Given this list of marker genes Zmynd11, Hras, Ckmt1, Mir19b-1, Pam16, Gstp3, Tsc22d3, Ncl, Pttg1ip, Rps6ka1, Htt, Ramp2, Dyrk3, Klhl20 (NCBI Gene Id 98385), Erbb2, Hsp90b1, Mir292, Hspb2, Nod2, Mir93, Cx3cr1, Aifm2, Atad3a (NCBI Gene Id 71964), Lep, Nono, Fnta, Tcim, Prkdc, Grik2, Irs2, Tmbim6, Pcid2, Ffar4, Notch1, Hsp90ab1, Rock1, Hmga2, Mapk8ip2, Arhgap10, Kank2, Bcl2l12, Dnajc3, Flt4, Bcl3, Pdpn, Lrrk2, Phip, Slc1a1, Lims1, Chd8, Fcgr2b, Zfand6, Sirt1, Stradb, Cib1, Ung, Tnf, Ctnnb1, Rxfp2 (relaxin/insulin-like family peptide receptor 2), Hypk, Taf9, Insl3, Vtcn1, Kifap3, Alms1, Nr4a3, Rad21, Smo, Pdk4, Casp2, Cabin1, Pdxk, Tfap2d, Adam8, Atg7 (autophagy related 7), Sox8, Tmf1, Dspp, Cdc73, Csf2, Higd1a, Slc7a5, Bbs10, Lhx3, Grem1, Eif2a, Nnt, Oxr1, Gbe1, Fas, Ddias, Igf1r, Trp53, Pak4, Pink1, Vdac1, Fga, Pdgfrb, Rack1, Serpinb9g, Coro1a, Nr1h4, Epha4, Grk2, Tnfrsf23, Tsc22d1 (TSC22 domain family, member 1), Vegfa, Anp32b (NCBI Gene Id 67628), Bcl2, Serpinb9c, Ptcra, Nupr1 (NCBI Gene Id 80556), Glo1, Fzd1 (NCBI Gene Id 14362), Rgl2, Eif5a, Grm7, Pcp4, Mdm2, Itgb1 (NCBI Gene Id 70812), Kitl, Rnf7, Cav1, Csnk2a1, Ascl1, Asns, Tmem215, Npy5r, Cxcr3, Rnu12, Por, Arnt2, Gata2, Sct, Smarca4, Dusp1, Birc5 (NCBI Gene Id 11799), Becn1, Dsg2, Mael, Scg2, Apoe, Egfr, Aamdc, Nrbp2, Hif1a, Alox12, Egr3, Eya2, Ybx3, Pcdhgc3, Mnat1, Hand2, Gch1, Tle1, Ube2z, Ntf3, Tnfsf4, Ghitm, Mir92-2, Nkx3-2, Axl, Plxnd1, Icam1, Slc9a1, Cebpb, Arf4, Ell3, Tfap2a, Naa15, Asic2, Mecp2, Zfp385a, Ltk, Gcm2, Hnf1a, Il7r, Pdx1, Pdcd1, Bhlhb9, Vdac2, Pin1, Evi2b, Hsph1, Il3, Acot1, Grin1, Mydgf, Pdpk1, Trip10, Ednra, Ntrk1, Gapdhrt2, Tnfrsf1a, Prkcz, Ccn1, Fkbp8, Msx2, Isl1, Apip, Gata4, Hspa8, Bag6, Brca1, Golph3, Tmbim4, Cdkn1b, Fgf4, Wnt1 (NCBI Gene Id 22408), Pou3f3, Nr3c1, Dpp8, Pik3cg (NCBI Gene Id 76039), Aqp1, Hsh2d, Bok, Vstm2l, Tmem109, Ccl5, Mfn2 (NCBI Gene Id 170731), Mir293, Caap1, Fgf21, Blvra, Cacna1a, Foxc1, Eef2k, Il6st, Ccl19-ps6 (C-C motif chemokine ligand 19, pseudogene 6), Rbck1, Mapk8ip3, Naa16 (NCBI Gene Id 66897), Noc2l, Hdac2, Mif, Efna1, Cdkn2d, Hmgcr, Mt3, Yme1l1, Bnip3, Prdm9, Hnrnpk, Prelid1, Tgfb3, Tjp1, Ccl19-ps4, Ndufa13, Psme3, Plac8, Map2k5, Mre11a, Ntsr1, Herpud1, Cpeb4, Mir25, Pa2g4, Plcg2, Atoh1, Ufm1, Adar, Pin1rt1, Ppp1r10, Serpinb2, Cflar, Itga6, Bard1, Nos1, Tbx1, Gas1 (growth arrest specific 1), Ndufs3, Cdk11b, Nfatc4, Slc39a10, Gpam, Map3k7, Rps6kb1, Ptgs2, Gcg, Gata6, Pim2, Ccnd2, Npc1, Gdf5, Twist2, Mir106a, Rgn, Mir20a, Oog3, Hey2, Nr4a2, Timp1, Niban2 (NCBI Gene Id 227737), Wfs1 (NCBI Gene Id 22393), Fgf10, Maea, Hnf1b, Itprip, Fmn2, Stk40, Tslp, Ptk2b, Gapdh, Grk1 (NCBI Gene Id 24013), Bcl11b, Ambra1, Ptrh2, Ccl19, Pou3f4, Pax2, Cbl, Tcf7, Camk1d, Proc, Grina, Sycp2, Aars1, Bcl2a1a, Mir294, Nme5, Rpl10, Pkhd1, Foxb1, Sphk1, Faiml, Btc, Myc, Mgmt, Myocd, Foxo1, Mrtfa, Mdk, Bfar, Xpnpep1, Hspb6, Met, Pik3r1, Tmbim1, Hmgb2, Prokr1, Ngf (nerve growth factor), Cited1, Lcn2, Fbxo7, Lgmn (NCBI Gene Id 19141), Nat8b-ps, Foxq1, Slc46a2, Epor, Pramel7, Ada, Lmna, Abl1, Apbb2, Rbfox2, Prkca, Ndufaf4, Prop1, Jak3, Srsf6, Park7, Pcdhgc4, Prkch, Cdkn1a, Cxcl12, Creb1, Atf5, Abraxas2, Bmf, Taf9b (TATA-box binding protein associated factor 9B), Ppif, Nefl, Ghrh, Cblb, Opn3, Epcam, Pdcd10, Faim, Gpx1, Fcer1g, Plaur, Grk5, Optn, Mir106b, Twist1, Nqo1, Hsf1, Serpinb9f, Osr1, Pramel1, Ercc5, Xrcc4, Ddx3x, Kcnh8, Pim1, Dpep1, Fgfr2, Tbx3, Rpl10-ps3, Msh2, Btg2, Madd, Xbp1, Rffl, Flna, Nppc, Xiap, Itgav, Card14, Clec5a, Ccl19-ps1, Ednrb, Glp1r, Ucp2, Drd3, Chst11, Prdx5, Esr2, Tgfb2, Pak2, Jun, Spry2, Mtor, Il19, Hyou1, St6gal1, Bax, Map2k1, Pcgf2, Prkcq, Birc7, Klf4, Prr5, Erfe (erythroferrone), Hcls1, Cep63, Agtr1b (angiotensin II receptor, type 1b), Asah2, Lhx4, Map4k4, Gpi1, Foxp1, Agtr2, Retreg1, Casp8, Slc40a1, Itpr1, Sod1, Pik3cb, Syvn1, Tmem161a, Stxbp1, Laptm5, Naip6, Cryab, Myo18a, Ccl21f, Dipk2a, St3gal1, Bcl10, Dock8, Slc25a27, Krt18, Tax1bp1, Nrg1, Stub1, Abcc9, Marchf7, Mtnr1b (melatonin receptor 1B), Smad6, Ptms (NCBI Gene Id 69202), Gria4, Cd38 (CD38 antigen), Arl6ip1, Eno1b, Akr1b1 (aldo-keto reductase family 1 member B), Mfsd8, Dhrs2, Trap1, Gimap3, Creb3l1, Prok2, Ccr5, Kdm2a, Map3k12, Kdr, Hipk3, Fgf2, Syngap1, Fmr1, Avp, Bhlhe23, Hax1, Gstp2, Tgfa, Triap1, Ing2, Gnai3, Pepd, Prlr, Lrp2, Wnk3, Ogg1 (8-oxoguanine DNA-glycosylase 1), Gnaq, Map2k4, Ciapin1, Lrp6, Smad5, Sox9, Ntf5, Mcl1, Ppara, Faim2, Mapk8ip1, F2r, Shc1, Bak1, Fadd, Cited2, Msx1, Il13, Ccnd1, Maz, Cth, Adora1, Tcf7l2, Ccl19-ps5, Tigar, Adamts20, Sh3glb1, Serpine1, Ctns, Bmi1, Ccl21a, Muc4 (mucin 4), Selenos, Supv3l1, Ptprz1, Ier3ip1, Crhr1, Dll1, Dnaja1, Dnaja3, Kdm2b, Ngfr, Bag5, Fgg, Hip1r (huntingtin interacting protein 1 related), Epo, Rps6, Rnf34, Serpinb13, Shh, Mical1, Fgb, Dstyk, Qars1 (NCBI Gene Id 97541), Serpinb9e, Ackr3, Atad5, Atp6v0c, Grn, Insl6, Pias1, Il2rb, Naa38, Eya1, Jak2, Clu, Ghsr, Bdnf, Ddr2, Fxn, Rnf144b, Nuak2, Fgf20, Crlf1, Nfe2l2, Ern1, Barhl1, Bnip3l-ps, Ddb1, Igbp1, En1, Ctsh, Braf, Lypd3, Rrm2b, Fignl1, Higd2a, Gclc, Ufl1, Ppargc1a, Wt1, Vps54, Kras, Ube2b, Tnip2, Rnf31, Cd2ap, Tnfrsf18, Pik3ca, Npm1, Erbb3 (NCBI Gene Id 97627), Snai2, Cops5, Fzd9, Oog2, Lims2, Il7, Slc7a11, Aurka, Adcyap1, Gas6, Ddrgk1, Pim3, Ngb, Eya3, Gnrh1, Rictor, Mutyh, Csf1r, Tex11, Daxx, Akt1, Cln8, Muc1, Gpx4, Itga5, Atf4, Tm7sf3, Rln1, Pdcd4, Il1rn, Comp, Yap1, Hmgn5, Ccl12, Mertk, Adora2a, Pcdhgc5, Prkcg, Spp1, Mpv17l, Kdm1a, Ccng1, Dnmt1, Sgk1, Ltf, Aurkb, Bag1, Dnajc5 (NCBI Gene Id 99185), Sfrp2, Prkn, Txndc12, Il10, Mdm4 (transformed mouse 3T3 cell double minute 4), Wnt16, Krit1, Mien1 (NCBI Gene Id 66428), Tnfaip3, En2, Ppia, Serpinb9d, Fzd3, Actc1, Sh3rf2 (NCBI Gene Id 269016), Ghrl, Xrcc2, Gapdhrt, Ints1, Sh3rf1, Rapgef3, Apc, Il27ra, Gsk3b, Qki, Ptma, Api5, Med1, D1Pas1, Bad, Rps3a1, Ago4, Ilk, Uri1, Kif14, Cd59a, Eif2ak3, Angpt4, Bag3, Lifr, Casp3, Mnt, Hspa5, Wnt4, Atg5, Ncam1, Trim32, Gba1, Birc2, Gfer, Il2, Eya4, Raf1, Tmem132a, Plk1, Pycr1, Nanos3, Snai1, Pten, Pafah2, Cidea, Thap11, Hipk2, Cblc, Prnp, Wnt5a, Nr2e1, Hspb1, Ucn, Pax8, Pou4f1, Ttpa, Zpr1, Tnfrsf22, Dad1, Acaa2, Ywhah, Fhl2, Bmp4, Tnfrsf4, Naip5, Gli3, Fth1, Gstp-ps, Bcl2l2, Plk3, Akt2, Fate1 (NCBI Gene Id 77905), Mir20b, Slc25a5, Adam17, Ccl21e, Nfkb1, Pea15a, Vegfb, Slc25a4, Cerkl, Chl1, Snx6, Cfdp1, Itgb3, Prkaa1, Sox10, Arel1, Smad3, Slc35f6, Nat8f1, Ikbkg, Bcl2l10, Mapk8, Prdx3, Hck, Nckap1l, Slc25a31, Oog1, Flt3l, Rb1cc1, Id1, Mlst8, Opa1, Prkce, Rag1, Cttn, Nkx2-6, Mtdh, Psmg2, Abl2, Mir92-1, Nuggc, Adnp, Dab2, Mapkap1, Tyro3, Ar, Fabp1, Mtrnr2l7, Mpl, Lgals3, Col2a1, Mir18, Psmd10, Vip, Nrp1, Sema3e (sema domain, immunoglobulin domain (Ig), short basic domain, secreted, (semaphorin) 3E), Sgk3, Rnf157, Hspa1b, Hgf (NCBI Gene Id 15234), Parl, Phb1, Ifit3, Pak5, Kcnj1, Aipl1, Prkaa2, Trp73, Mapk7, Cntfr, Psen2, Mir363, Pth, Usp47, Gimap5, Serpinb9h, Arrb1, Lamtor5, Hk3, Armc10, Cx3cl1, Ccar2, Prkcd, Zc3h12a, Cat, Kdm6a, Apbb3, Snca, Son, Cbs, Ccl21d, Igf1, Gli2, Pde3a, Mitf, Gfral, Stambp, Arg2, Dapk1, Naip1, Blm, C5ar1, Scx, Cryaa, Pcnt, Foxe3, Birc3, Cd40lg, Nup62, Foxc2, Sirt5, Htr2b, Sin3a, Cdk1, Nme2, Sycp2l, Prkci, Adprs, Nog, Palb2, Sc5d, Ndnf (neuron-derived neurotrophic factor), Cftr, Capn3, Akr1a1, Tgfbr1, Mag (NCBI Gene Id 17136), Rb1, Ppef2, Ccl19-ps3, Dpp9, Six1, Ang, Thbs1, Mir18b, Clcf1, Hdgf, Nat8f7, Ihh, Smg9, Il18, Ptk2, Cast, Mef2c, Amigo2, Cdsn, Nes, Creb3, Itsn1, Pla2g3 (phospholipase A2, group III), Rhoa, Vhl, Lonrf2, Sirt4, Mdga2, Ncoa3, Ptpn1, Wdr73, Atox1, Siah2, Pidd1, Khdc3, Draxin, Tert, Prap1, Angptl4, Fyn, Pgr, Apoh, Gclm, Stat5a, Sema5a, Lef1, Tfrc, Naip2 (NLR family, apoptosis inhibitory protein 2), Itpkb, Trem2, Esr1, Angpt1, Six4, Mpz, Erbb4, Fn1, Fgf8, Rtkn2, Cln3, G2e3, Peli3, Aven, Bnip3l, Rorc, Mecom, Agt, Wnt9a, Ptgfr, Sirt2, Sfrp1, Araf, Unc5b (NCBI Gene Id 76853), Bcl6, Mst1, Stat5b, Il1b, Gdnf, Hhip, Ube2v2, Ormdl3, Nfix, Hpn, Cntf, Ripk1, Wnt7a, Il4, Tfap2b, Ppard, Psen1, Eno1 (enolase 1, alpha non-neuron), Nkx2-5, Naa35, Alkbh1, Traf2, Slc2a3, Pip, Mir17, Cd74, Agtr1a, Star, Rps6ka3, Dlx1, Pcmt1, Mmp9, Ccr7, Aatf, Agap2, Itch, Mir295, Bid (BH3 interacting domain death agonist), Gnai2, Arrb2, Tek, Bcl2l1, Cd27, Serpinb9, Lrp1, Aif1, Ctnna1, Cdh5, Stil, Prdx2, Zfp830, Edn1, Phb2, Ppp5c, Src, Cd59b, Ifit3b, Aldh2, Hk1, Nmnat1, Il6, Hells, Sqstm1, Mir19b-2, Nol3, Bdkrb2, Hspd1, Pax4, Acvr1 (NCBI Gene Id 11478), Pnp, Fstl1, Bmp7, Fank1, Mir290a, Mad2l1, Hdac1, Tmem14a, Ivns1abp, Sncb, Atp7a, Ntrk2, Ahi1, Tox3, Babam2, Sod2, Ankle2, Tgfbr3, Meis3, Birc6 (baculoviral IAP repeat-containing 6), Ppt1, Hmox1, Lig4, Itgb3bp, Tent5b, Ido1, Gstp1, Ier3 (immediate early response 3), Rhbdd1, Rela, Plk2, Ccl21b, Fcmr, Mt1, Peli1, Rrn3, Set, Rasa1, Neurod1, Serpinb9b, Dkk1, Dffa, Eif2ak2, Gata1, Tmigd1, Cxcr2, Kit, Tpt1, Cd44, Cldn7, Gata3, here is a description of the gene set: Mouse Gene Set: GOBP_NEGATIVE_REGULATION_OF_PROGRAMMED_CELL_DEATH studied in species Mus musculus Any process that stops, prevents, or reduces the frequency, rate or extent of programmed cell death, cell death resulting from activation of endogenous cellular processes.